Given this list of marker genes Actl6a (NCBI Gene Id 99742), Smarcb1, Brd7, Arid2, Actb, Smarcd1, Smarcc2, Pbrm1, Smarcc1, Phf10, Suz12, Actl6b, Smarce1, Smarca4 (SWI/SNF related, matrix associated, actin dependent regulator of chromatin, subfamily a, member 4), Smarcd2, here is a description of the gene set: Mouse Gene Set: GOCC_RSC_TYPE_COMPLEX A SWI/SNF-type complex that contains a bromodomain containing-protein, such as yeast Rsc1 or Rsc4 or mammalian PB1/BAF180. The RSC complex is generally recruited to RNA polymerase III promoters and is specifically recruited to RNA polymerase II promoters by transcriptional activators and repressors; it is also involved in non-homologous end joining. studied in species Mus musculus